Given this list of marker genes STAT1, SUMO1, PTPN11, SOCS3, PTPN6, IFNG, JAK2, PTPN2, PTPN1, SOCS1 (suppressor of cytokine signaling 1), PIAS1, JAK1, IFNGR2, IFNGR1, here is a description of the gene set: part of: Interferon gamma signaling Reactome Pathway: Regulation of IFNG signaling species: Homo sapiens At least three different classes of negative regulators exist to control the extent of INFG stimulation and signaling. These include the feedback inhibitors belonging to protein family suppressors of cytokine signaling (SOCS), the Scr-homology 2 (SH2)-containing protein tyrosine phosphatases (SHPs), and the protein inhibitors of activated STATs (PIAS). The induction of these regulators seems to be able to stop further signal transduction by inhibiting various steps in IFNG cascade.